The following is a description of a gene set: Human Gene Set: HP_HYPOLIPOPROTEINEMIA An abnormal decrease in the level of lipoprotein cholesterol in the blood. Hypolipoproteinemia studied in species Homo sapiens, and this is the list of marker genes: GALNT2, LIPA (NCBI Gene Id 3988), SLC25A13, ALMS1, SCAPER, SDCCAG8, SNORD115-1, NPHP1, BBS1, MKRN3, NGLY1, PWAR1, PCYT1A, ALG6, GBA1, BBS5, MTTP, TTC8, BBS2, LZTFL1, APOB (NCBI Gene Id 338), SAR1B, TRIM32, MKS1, SCARB2, SLC7A7, CFAP418, SMPD1, CREB3L3, MSMO1, CEP19, B4GALT1, CELA2A, AIP, CEP290, GPIHBP1, HERC2, LCAT, BBS10, PSMB8, BBS7, BBS12, NPAP1, GPR101, APOA1, ARL6, SNORD116-1, IFT74, MKKS, PPARG, MAGEL2, APOA5, APOE, PWRN1, ANGPTL3, APOC3, SCLT1, IFT172, LMNA (lamin A/C), FDFT1, IFT27, BBIP1, ABCA1, WDPCP, BBS9, LDLRAP1, BBS4, PLAAT3